Given this list of marker genes CNR2, FLNB, NR4A1, PTP4A3, PELI1, BID, SMAD3, GFOD1, PIK3AP1, UST, S1PR1, HES4, ZFP36L1, ENTPD1, MPEG1, HES1, SNN, TRAF4, FGD2, TOP1, SIK1, TNFRSF13B, GALNT6, IKZF1, BATF, LGMN, CLEC17A, NEDD9, PAX5, GALNT10, NEIL2, CD84, NOTCH3, ABHD6, ZMIZ1, CD82, ID2, IQSEC1, ADTRP, FCRL2, TRAM2, SPIB, CAMP, HEY2, RHOBTB1, GADD45B, B4GALT1, SH3TC1, SUSD3, CD28, TET2 (tet methylcytosine dioxygenase 2), UBALD2, TNF, PTPN6, ICAM1, HIVEP1, P2RY11, KAZN, IL10RA, TBC1D9, CUEDC1, POU2AF1, IFIT3, DSE, IL16, HPCAL1, XYLT1, CXCR5, DUSP16, BLNK, CBFA2T3, UBASH3B, FGR, IFNAR2, ZDHHC14, PLAC8, CHI3L2, CAMKK1, ZFP36, THEMIS2, LIN54, DNASE2, RILPL2, CD27, ARID1B, SASH3, IRF8, TNFRSF1B, RXRA (retinoid X receptor alpha), DENND2D, MX2, TLE3, CDC25A, ARHGEF3, IL6R, MAP3K5 (mitogen-activated protein kinase kinase kinase 5), FYN, PRICKLE1, TMPRSS3, DNMBP, PPAN, RAB11FIP4, EML4, SFTPB, GRN, RHOH (NCBI Gene Id 399), LY86, SSH2, BLK, BCL2A1, MYBL2, ARHGAP17, FMNL3, MYC, FCRL4, CHST10, ST6GAL1, NRARP, MGLL, SH2B2, LPCAT1, IL21R, DTX4, P2RX5, CDK5R1, IFNGR1, LDLRAD4, DNASE1L3, CD72, COQ2, RUNX3, DTX1, ARAP1, DUSP2 (NCBI Gene Id 1844), CR2, HASPIN, PTK2B, FCRL3, FAM167A (NCBI Gene Id 83648), TASP1, TNIP1, RHOV, ITGAL, CYLD, CD300A, LYN, SEMA7A, KLF13, here is a description of the gene set: Human Gene Set: RYAN_MANTLE_CELL_LYMPHOMA_NOTCH_DIRECT_UP Gain-of-function Notch mutations are recurrent in mature small B cell lymphomas such as mantle cell lymphoma (MCL) and chronic lymphocytic leukemia (CLL). We identified Notch-activated genes via rapid washout of gamma secretase inhibitor in MCL cell lines with activating Notch gene rearrangements, or that had been pre-stimulated by immobilized Notch ligand. We performed integrative analysis of Notch-regulated transcripts, genomic binding of Notch transcription factor complexes, and genome conformation data to identify direct Notch target genes in MCL cell lines. Likely indirect target genes (MYC-activated genes) were excluded by Notch activation experiments conducted in a cell line in which MYC expression was independent of Notch due to a genomic rearrangement of the MYC locus. This B cell Notch regulome is largely controlled through Notch-bound distal enhancers and includes genes involved in B cell receptor and cytokine signaling. We show that the oncogene MYC sustains proliferation of Notch-dependent MCL cell lines via a Notch-regulated lineage-restricted enhancer complex. Expression of direct Notch target genes is associated with Notch activity in an MCL xenograft model and in CLL lymph node biopsies. from publication Ryan RJH, Petrovic J, Rausch DM, Zhou Y, Lareau CA, Kluk MJ, Christie AL, Lee WY, Tarjan DR, Guo B, Donohue LKH, Gillespie SM, Nardi V, Hochberg EP, Blacklow SC, Weinstock DM, Faryabi RB, Bernstein BE, Aster JC, Pear WS (PMID 29045844) Genes upregulated by rapid Notch activation and linked to Notch TF binding peaks in mantle cell lymphoma cell lines. species: Homo sapiens